The following is a description of a gene set: The third pass through the beta-oxidation spiral picks up where the last left off with the saturated fatty acid lauroyl-CoA and produces decanoyl-CoA. Four enzymatic steps are required starting with LCAD CoA dehydrogenase (Long Chain) activity, followed by the enoyl-CoA hydratase activity of crotonase, the 3-hydroxyacyl-CoA dehydrogenase activity of the short chain 3-hydroxyacyl-CoA dehydrogenase (SCHAD), and completed by the ketoacyl-CoA thiolase activity, present in the mitochondrial membrane associated trifunctional protein. Note that the 3-hydroxyacyl-CoA dehydrogenase activity of SCHAD is not actually limited to short chain fatty acids, in fact SCHAD has a broad substrate specificity. studied in species Homo sapiens Reactome Pathway: Beta oxidation of lauroyl-CoA to decanoyl-CoA-CoA part of: mitochondrial fatty acid beta-oxidation of saturated fatty acids, and this is the list of marker genes: HADHA, ECHS1, ACADL, HADH, HADHB